Given this list of marker genes SKP2, SKP1, RBX1, FBXL17, UBA52, MAFK, UBC, BACH1, UBB, CUL1, RPS27A, here is a description of the gene set: species: Homo sapiens Regulation of BACH1 activity Human Gene Set: REACTOME_REGULATION_OF_BACH1_ACTIVITY